Given this list of marker genes EXOSC2 (exosome component 2), CHST6, CRYAA, TRIM37, MAB21L1, SLC25A4, GSN, DCN, SLC4A11, PRDM5, MCOLN1, PIKFYVE, OPN1LW, CHRDL1, ZEB1, AGK, ZNF469, GNAQ, TACSTD2, OPN1MW, TGFBI, CYP4V2, MAF, GJA8, CRYBB1, MBTPS2, UBIAD1 (NCBI Gene Id 7801), KRT12, COL8A2, CRYBB2, AGBL1, GLA, COL17A1, CRYBA4, CRYGC, TKFC, CRYGD, here is a description of the gene set: Corneal dystrophy Human Gene Set: HP_CORNEAL_DYSTROPHY The term corneal dystrophy embraces a heterogenous group of bilateral genetically determined non-inflammatory corneal diseases that are restricted to the cornea. studied in species Homo sapiens